The following is a description of a gene set: GRB2 events in ERBB2 signaling studied in species Mus musculus Mouse Gene Set: REACTOME_GRB2_EVENTS_IN_ERBB2_SIGNALING, and this is the list of marker genes: Ereg (NCBI Gene Id 269673), Nrg3, Erbb4, Erbb2, Kras, Hbegf, Hras, Sos1, Grb2, Nrg1, Btc